Given this list of marker genes ANXA1, CFLAR, GFI1B, PCNA, OSBPL3, NCKAP1, VAMP4, CADM3, CEP170, GCNT2, MMP25, OMG, ACTL7B (actin like 7B), EXOC2, CHIT1, IL18RAP, ASTE1, BMAL1, CTSC, HTR2C, KCNJ8, RAP1GAP2, EPPIN, TRAF6, DNAJC22, SCN8A, UPRT (NCBI Gene Id 139596), PLA2G4F, SIKE1, CAPG, LAMB3, BCORL1, IL2RA, IQCB1, CAPNS1, CLEC9A, DNM1, FCGR2B, IRF4, AGTR2, RFX6, SYT8, METRNL, HAVCR2, ITGAL, CYFIP1, GDF2, ARHGAP26, FASTKD1, NPTX2, XRN1, DUSP29, BICD1, SYPL1, CAPN2, ITM2B, CDHR1, REEP5 (NCBI Gene Id 94845), PLXNA3, TMEM67, STARD10, IL9, PERP, PRDM11, EMP3, CCDC88C, SERPINB11, RAP2C, KLRC1, ARID1B, LAMC1, TMEM106A, UBASH3B, JUP, KRTAP3-3, YPEL5, DLG4, CYTH4, PLPP1, GABBR1, FAR1, PLCH1, GPD2, EPS8, NGB, NOTCH3, SERPINB9, THEMIS, RORA, DGKH (NCBI Gene Id 8524), SOWAHC, ADAP2, PLEKHF1, GABARAPL1, ARL15, ZBBX, MED13, RSU1, MINDY3 (MINDY lysine 48 deubiquitinase 3), LGALS3, TMPRSS13, KRTAP17-1, CROT, ADAMTS6, GSAP, IL18R1, PNLIP (pancreatic lipase), ATP2B1, SLAMF7, ERN1, GSPT2 (G1 to S phase transition 2), RAC1, MT1A, NDFIP2, CD226, TRIM46, RAP1B, CCL26, JAK1, NR1D2, LPIN1, SNAPC3, CX3CR1, SPMAP2 (NCBI Gene Id 91957), NCAN, FIG4, GSS, ADAMTS14, KLRC2, PLCZ1, PIK3AP1, SLAMF1, MYOM2, ATP8B4, TPMT, KLF17, LGALS1, ARHGEF12, GNGT1, PLSCR4, DOCK10, LIPK, MYL6B, CD80, OOSP1, STON2, here is a description of the gene set: species: Homo sapiens from publication Kress E, Hedges JF, Jutila MA (PMID 16423401) The two major human gd T cell subsets, Vd1 and Vd2, display differences in tissue tropism and agonist responses, but we have little insight into global differences that may exist at the gene expression level. This is due to the small numbers of these cells that can be obtained from healthy donors, which limit comprehensive, comparative gene expression analyses. We established a culture method that expands Vd1 and Vd2 cells from the same PBL preparation to levels sufficient for sorting and microarray analysis. Although the subsets were expanded identically (anti-TCR mAb, plus IL-15), 392 and genes were identified, which were differentially expressed in the two subsets, from two donors, respectively. Approximately genes changed in both subsets following PMA/ionomycin treatment; about 50% of these genes were subset-specific. Both subsets responded to a crude LPS preparation, but only 6% of the responsive genes were the same. The differentially expressed genes were consistent with Vd2 cells being more inflammatory and Vd1 cells having more of a regulatory phenotype. Both subsets expressed transcripts encoding an array of innate and NK cell receptors, supporting the relationship of gd T cells to the innate immune system. Our results show that circulating Vd1 and Vd2 subsets in humans have considerable, inherent differences in gene expression following treatment with non-TCR agonists, supporting unique functional roles for these cells in vivo. Human Gene Set: GSE3720_UNSTIM_VS_LPS_STIM_VD1_GAMMADELTA_TCELL_DN Genes down-regulated in Vd1 gamma delta T cells: untreated versus LPS.